The following is a description of a gene set: Aplasia/Hypoplasia of the gallbladder Human Gene Set: HP_APLASIA_HYPOPLASIA_OF_THE_GALLBLADDER Absence or underdevelopment of the gallbladder. studied in species Homo sapiens, and this is the list of marker genes: FOXF1 (NCBI Gene Id 2294), CNOT1, CC2D2A, INTU, GATA6, SON, RFX6